Given this list of marker genes STK17A, SON, SLA, TNFRSF9, CCL5, ATP8A1, SYNE2, GBP5, TENT5C, SRSF7, PTPN22, TNIP3, RASAL3, HLA-B, ARAP2, HERPUD2, NR4A2, JAKMIP1, GUK1, SH2D1A, CCNH, JMJD6 (NCBI Gene Id 23210), PARP8, CAPN2, UBC, TRG-AS1, MIAT, RNF19A, TIGIT, A2M-AS1, FYN, IFNG, CXCR6, KIF21A, CD8B, GZMK, MT1F, GZMH (granzyme H), LINC03057, RGS1, DUSP2, F2R, LINC00987, CD99, PATL2, TRGC2, ATG2A, ITGB1, TPRG1, CLEC2B, KIF19, LYAR, SLAMF6, CRTAM, PPP2R5C (NCBI Gene Id 63377), KLRG1, MFSD10, LAG3, LINC02937, PPDPF, CD8A, ZNF683, CHI3L2, PRDM1, MSC, PTPN7, ENC1, PTPRC, LINC01871, TTC16, TMA7 (NCBI Gene Id 51372), IL32, CXCR4, here is a description of the gene set: from publication Hay SB, Ferchen K, Chetal K, Grimes HL, Salomonis N (PMID 30243574) Human Gene Set: HAY_BONE_MARROW_CD8_T_CELL species: Homo sapiens